The following is a description of a gene set: Spondylometaphyseal dysplasia Human Gene Set: HP_SPONDYLOMETAPHYSEAL_DYSPLASIA studied in species Homo sapiens, and this is the list of marker genes: TRIP11, PAM16 (presequence translocase associated motor 16), FN1, ACP5, PCYT1A, GPX4, COL2A1, CFAP410, TRPV4 (transient receptor potential cation channel subfamily V member 4)